Given this list of marker genes Insm1, Lhx2, Adcyap1, Trp53, Mapk8, Cx3cr1, Shcbp1, Notch1, Ell3, Otp, Btg2, Gpr37l1, Nog, Kdm1a, Dct, Shh, Lims2, Lims1 (NCBI Gene Id 71899), Id2, Gli2, Ccr5, Nrg1, Prdm4 (NCBI Gene Id 73308), Sbno1, Ctnna1, Gnai2, Igf1, Rapgef1, Afdn, Ascl1, Cdh2, Dmrta2, Rassf10 (Ras association (RalGDS/AF-6) domain family (N-terminal) member 10), Aspm, Il1b, Tox, Ctf2, Disp3, Nap1l1, Foxg1, Foxo1, Vsx2 (visual system homeobox 2), Disc1, Ngfr, Rhoa, Tafa1, Sox2, Nr2e1, Bdnf, Zfp423, Gjc2, Prl2c2, Bex1, Appl2, Sall1, Pax6, Mdk, Fzd3, Sox10, Kctd11 (NCBI Gene Id 216858), Lhx5, Flna, Emx1, Skor2, Ilk, Vax1, Cx3cl1, Gata2, Kdm2b, Setd1a, Prox1, Optn, Smarcd3, Ptprz1, Spint1, Ctnnb1, Six3, Wdr62, Trf, Lyn, Nf2, Slc6a4, Wnt3a, Pde9a (NCBI Gene Id 18585), Zfp335, Kifap3, Mup20, Cdon, Sirt2, Fgf2, Gli3, Fgfr3, Ryk, Spint2, Nes, Rsu1, Gak, Egf, Adgrg1, Pitx3, Itgb1, Lrrk2, Mir574, Shoc2, Lrp2, Hif1a, Cip2a, Foxo3, Erbb2, Smarca1, Vegfa, Tgfb1, Cd24a, Slc16a2, Drd2, Ntrk3, Gli1, Fzd9, Nf1, Ptbp2, Vegfc, Cend1, Hdac5, Gng5, Dll4, Smo, Ptn, Wnt5a, Trim71, Id4, here is a description of the gene set: Mouse Gene Set: GOBP_REGULATION_OF_NEURAL_PRECURSOR_CELL_PROLIFERATION species: Mus musculus Any process that modulates the frequency, rate or extent of neural precursor cell proliferation.